The following is a description of a gene set: Human Gene Set: GOMF_PHOSPHATIDYLINOSITOL_3_5_BISPHOSPHATE_BINDING Binding to phosphatidylinositol-3,5-bisphosphate, a derivative of phosphatidylinositol in which the inositol ring is phosphorylated at the 3' and 5' positions. species: Homo sapiens, and this is the list of marker genes: TPCN1 (two pore segment channel 1), WIPI1, CLVS1, PLEKHA4, WIPI2, COMMD1 (copper metabolism domain containing 1), PHLDA3, SNX3, ATP13A2, WASHC2C, SNX5, WDR45B, CLVS2, SNX14, SESTD1, TPCN2, MAPKAP1, HIP1R, PLA2G4E, RAG2, JPH2, KIF16B, HIP1, SH3PXD2B, WDR45, GBF1, PLEKHA5, PLEK2